Given this list of marker genes FNBP1L, CYB5R3, HSPA9, ZNF225, ZNF557, SLC4A3, EML4, ZNF35, RAP2C, LAMP1, CYB5A, ECI1, CEP83, NBN, P2RY13, SLFN12, NCK2, ERAP1, TRIM28, CDC14A, N4BP2L2, ATF3, LAT, JUN (Jun proto-oncogene, AP-1 transcription factor subunit), KPNA3, SMC4, GABBR1, CAMKK2, NECAP1, RCBTB1, LILRA2, TENT5A, CAB39L, XRCC4, ACSL1, RCHY1, IFFO1, VPS33B, BRWD1, SRSF10, SMC5, ZNF410, CHD3, EXOC3, ITPR1, MLEC, UPP1, TRIM33, CREG1, ERP44, SAP25, UBE2I, PLEKHA5, EXOSC2, BTG1, POLR3K, CALM1, HIC2, ATP7A, ADAM19, ZNF629 (zinc finger protein 629), PKP4, NIPBL, WDR59, NOC3L, KLC2, TCF3, ANKHD1, MTMR2, CLPX, PLA2G4C, PSME4 (NCBI Gene Id 23198), AKAP9, SNRPA1, ASXL2, MDM2, AMY1B (NCBI Gene Id 277), PTBP2, AHCTF1, FUS, PKD2, SIGLEC9, SMAP1, SFN, MTR, DIPK1A, ZMYM4, CBR1, RNF19B, RO60, MDH2, ABCC1, STK39, DNAJC16, SMYD2, BAIAP2, P2RY14, RUNX3, FPR3, WASHC4, SLC20A2, ACOT11, ACBD3, USP9X, NOTCH2, RHOT1, ATF5, SGCE, RALGAPB, METTL22, FDFT1, ACLY, AMY1C, LEMD3, NADSYN1, SLC39A6 (solute carrier family 39 member 6), OSBPL3, CCL3, VWA5A, METAP1, KLF2, AASDHPPT, NOL12, FGR, LARP4B, ITGB1, GABPB1-IT1, NCK1, ASB13, POLA1, OPN3, IFIH1, TMEM41B, GSK3B, FAM13B, FIP1L1, SLF2, TRIAP1, UBN1 (ubinuclein 1), STX18, UBAP2L, PTPN9 (NCBI Gene Id 5780), DEPDC5, PDLIM5, SH3GL1, BCAP29, RETSAT, WSB1, STK38, MUTYH, KDELR1, NCF1C, PFKL, AMFR, THADA, PHTF2, TUBB3, TACC3, MAP7, LRP5L, NCF1 (neutrophil cytosolic factor 1), RNGTT, PRPF39, SNX11, SLA, RAD17, GNAI3, FOXP1, TP53TG1, YTHDC2 (YTH N6-methyladenosine RNA binding protein C2), MZT2B, SETDB1 (NCBI Gene Id 9869), FLT3LG, MAN2C1, EOLA1, TBCE, CCL3L3 (NCBI Gene Id 730422), GADD45B, SPPL2B, PELO, ARFGEF2, H2BC12, URI1, SOCS6, PLA1A, GOLT1B, ATF6, BTAF1, CCNG2, DCAKD, ZBTB22, GPR107, ANKHD1-EIF4EBP3, FKBP11, HPS1, TCIRG1, STX12, SRRM2, CITED2, TOMM34, PLPP1, NSG1, SRSF7, PHIP, MAP1LC3B, SOAT1, ATR, MECP2, GON4L, DPH1, SCAF4, TSC22D2, RABGAP1L, PAXBP1, CEP57, ZBTB20, ELOVL5, SOCS3, RIOK3, OTUD4, CD72, SULT1A2, ARL4A, ISG20L2, TP53BP1, TAPBP, NUP43, MAST2, LYRM9, AHCYL2, DHDDS, PCGF3, ITGAX, CTNND1, FNTA, SULT1A3, SLC33A1, TMED5, DXO, NUP58, SENP6, RSRP1, SULT1A4, CCDC59, CREB5, GSAP, ZCCHC10, LANCL1, SPIN2A, PUM2, HLA-DOB, SOD2, MTRR, RFX5, NLRP3, USP4, ATG9A, CYB5B, NUP50, LY96, TNFAIP8, C10orf88, LMBR1L, RASGRP1, ATP6V1B2, PDE4A, GNAS, HSPBAP1, TAF10, TARBP1, UBQLN2, TAF1B, POLR1C, PCNX2, HLA-DRB4, TRAPPC11, RAP2A, RANBP9, ADAP1 (NCBI Gene Id 11033), PRPSAP1, SAMD4A, RABAC1, MED7, LRRFIP2, GTF2H1, CPD, TRAK2, SECISBP2L (NCBI Gene Id 9728), MCTS1, NXT1, SEPHS1, CEP68, SSBP1, COX5B, BTN2A1, BAG6, SPAG9, RAF1, RPGR (retinitis pigmentosa GTPase regulator), SUN1 (NCBI Gene Id 80226), LRCH4, SLC30A1, TCP1, LYL1, ST8SIA4 (NCBI Gene Id 7903), PARP4, TXNL4A, SF1, AMY1A, MYH10, LDOC1, ZXDB, TTLL5, ATMIN, TIA1, ALG13, FDPS, VDAC1, AMY2B, TBC1D9B, IRF2, CNOT9 (NCBI Gene Id 9125), IL1B, IFITM2, MAP3K14, PKNOX1, SAP30, TRAPPC12, SPNS1, OSGIN2, EXOSC9, ZDHHC6, RCAN3, ATG13, RBM25 (NCBI Gene Id 58517), MAPK14, NTAN1, GBP1, GNAQ, FKBP15, EIF2S1, SLC35D2, ZFP64, STK38L, CMTR1, LONP2, CEBPB, MARCHF1, BICRAL, TWF1, TRIB2, RRN3P1, SCAPER, SP100, PACS1, LMBRD1, TFIP11, EOLA2, TNIP2, CSE1L, HNRNPA0 (heterogeneous nuclear ribonucleoprotein A0), MSRB2, ERG28, COPS8, CCDC86, SLC11A2, RGCC, RPA2, SPTLC1 (serine palmitoyltransferase long chain base subunit 1), AKAP13, HCAR3, NADK, MAN2A2, FBXO21, ACTN4, SRD5A1, BAZ2B, DTNA (NCBI Gene Id 86552), SULT1A1, PTPN22, ZFR, UBE2K, ABRAXAS2, NFATC2IP, SF3A1, ATP9B, ZNF544, CCP110, CD226, NCF1B, AMY2A, TSEN34, TCF20, RBFA, OVCA2, PITPNA, RASSF1, FN3KRP (fructosamine 3 kinase related protein), IQSEC1, here is a description of the gene set: from publication Nakaya HI, Wrammert J, Lee EK, Racioppi L, Marie-Kunze S, Haining WN, Means AR, Kasturi SP, Khan N, Li GM, McCausland M, Kanchan V, Kokko KE, Li S, Elbein R, Mehta AK, Aderem A, Subbarao K, Ahmed R, Pulendran B (PMID 21743478) Here we have used a systems biology approach to study innate and adaptive responses to vaccination against influenza in humans during three consecutive influenza seasons. We studied healthy adults vaccinated with trivalent inactivated influenza vaccine (TIV) or live attenuated influenza vaccine (LAIV). TIV induced higher antibody titers and more plasmablasts than LAIV did. In subjects vaccinated with TIV, early molecular signatures correlated with and could be used to accurately predict later antibody titers in two independent trials. Notably, expression of the kinase CaMKIV at day 3 was inversely correlated with later antibody titers. Vaccination of CaMKIV-deficient mice with TIV induced enhanced antigen-specific antibody titers, which demonstrated an unappreciated role for CaMKIV in the regulation of antibody responses. Thus, systems approaches can be used to predict immunogenicity and provide new mechanistic insights about vaccines. Human Gene Set: NAKAYA_MYELOID_DENDRITIC_CELL_FLUARIX_FLUVIRIN_AGE_18_50YO_7DY_UP species: Homo sapiens Genes up-regulated in myeloid dendritic cell 7d vs 0d in young adults (18-50) after exposure to Fluarix/Fluvirin, time point 7D